Given this list of marker genes PHLDA1, DGUOK, NPC1, SNRNP27, BNIP3, STC1, PIKFYVE, VRK2, UBA6, HERC5, ISG20, DTWD1, EPHA2, PYGL, HIF1A, PCGF1, PNRC1, RIPK2, SAT1, CTBS, PDP1, ARHGEF18, ANKRD28, OSMR, PGS1, UCKL1, SLC33A1, RRAGC, NIT1, ZMYM6, TMEFF1, GALE, RNF31 (NCBI Gene Id 80191), ADGRE5, SERPINB1, ABCA1, HEXB, EIF1B, ETS2, STAT3, TM4SF1, SLC12A7, S1PR1, RABGGTA, MOSPD2 (motile sperm domain containing 2), GRN, IL1RAP, TIMP1, CFHR3, GAS1, SOD2, IL1A, GSDME, STAM, TAB2, OXR1 (oxidation resistance 1), PTX3, RGS2, NT5E, IRF2, KLF2, SERPINE2, RAB29, RND3, GALNT2, SLC2A3, IRF7 (interferon regulatory factor 7), EIF1, P4HA1, EPAS1, OLR1, GCH1, LHFPL2, FGD6, RGS17, ZNF45, PROS1 (protein S), ZMYM1, ANXA3, LOX, IFITM1, BCL2L1, SIGIRR, ANXA7, SLC39A8, LARP6, TMEM59, ZNF200, AGFG1, TOR4A, CAAP1, ANKRD46, STON1, P2RX4, JUNB, GTPBP2, ZNF140, GATAD1, MRPS18A, EGLN1, PMAIP1, FOSL1, SOCS3, TJP2, PROCR, FBXO28, SLC1A4, CDCP1, PDE4B, CTSB, SEMA4C, CASP4, TNIP2, RBM7, ADGRG6, EREG, ARHGEF2, TAP1, NMI, SLC35G2, CLEC2B, MPG, GSDMD, CYB5R2, PLOD1, SLCO4A1, CXCL3, IL1R1, BCL3, RNF41, MAP3K5, ZFAND1, CANT1, CREM, SNAPC1, NEDD4L, PAPPA, DENND1A, DOCK4, SNAP23, TEAD4, MAK16, UPP1, SIAH2 (NCBI Gene Id 6478), GLRX, MMP3, KCNG1, ALDOC, PPM1D, MFF, DUSP1, PELI1, CARHSP1, YTHDC2, CFH, NR1H2, CA9, NARF, CSF3, DHRS7, ARPC5L (actin related protein 2/3 complex subunit 5 like), TNFAIP1, IFNGR1, PLAUR, IFI35, SERPINA1, EEF1A2, VEGFA, FST, PARP8 (poly(ADP-ribose) polymerase family member 8), EVI2A, LGALS8, YBX3, HTRA2, TNFAIP8, CYTH1, PLSCR1, C1R, FYN, CYBC1, SBNO2 (strawberry notch homolog 2), UGCG, IL15RA, FBXL5, BCL2A1, HAX1, TNFRSF6B, C1S (complement C1s), WIPI1, MRPL9, ROBO3, RPL36, CSNK2B, WARS1, IL6, RNF19B, MME, UAP1, EPN2, UBXN4, CD68, IL7, ACSL3, IVNS1ABP, IER2, EVL, MAPK14, TNFRSF21, BMAL2, HEXA, MTUS1, LY96, DCTN6, ANGEL2, IL1B, STAMBP, MID1IP1, INTS11, MTMR11, EVI2B, ITPKA, MOCOS, MYD88, PTPN2, PLAU, EHD4, FHL2, CTSL (NCBI Gene Id 1514), ALAS1, LAMP3, APPL2, ETHE1, STON1-GTF2A1L (STON1-GTF2A1L readthrough), VAMP4, CD55, TRAF4, LYRM1, PNP, TGIF1 (TGFB induced factor homeobox 1), IRF9, IFRD1, FUT8 (NCBI Gene Id 2530), here is a description of the gene set: Human Gene Set: HIRSCH_CELLULAR_TRANSFORMATION_SIGNATURE_UP Up-regulated genes in the cancer gene signature, representing a gene signature of cellular transformation. from publication Hirsch HA, Iliopoulos D, Joshi A, Zhang Y, Jaeger SA, Bulyk M, Tsichlis PN, Shirley Liu X, Struhl K (PMID 20385360) species: Homo sapiens Transcriptional profiling of two isogenic models of transformation identifies a gene signature linking cancer with inflammatory and metabolic diseases. In accord with this common transcriptional program, many drugs used for treatment of diabetes and cardiovascular diseases inhibit transformation and tumor growth. Unexpectedly, lipid metabolism genes are important for transformation and are upregulated in cancer tissues. As in atherosclerosis, oxidized LDL and its receptor OLR1 activate the inflammatory pathway through NF-kappaB, leading to transformation. OLR1 is important for maintaining the transformed state in developmentally diverse cancer cell lines and for tumor growth, suggesting a molecular connection between cancer and atherosclerosis. We suggest that the interplay between this common transcriptional program and cell-type-specific factors gives rise to phenotypically disparate human diseases.